Given this list of marker genes PAK5, SOS1, NCK2, NCK1, PAK1, SOS2, SLIT2, PAK4, PAK3, PAK2, ROBO1, RAC1, PAK6, here is a description of the gene set: A low level of RAC1 activity is essential to maintain axon outgrowth. ROBO activation recruits SOS, a dual specificity GEF, to the plasma membrane via Dock homolog NCK (NCK1 or NCK2) to activate RAC1 during midline repulsion. part of: Signaling by ROBO receptors Reactome Pathway: Activation of RAC1 species: Homo sapiens